Given this list of marker genes Set, Smpdl3a, Fth1, Psmd8, Coro1a, Gpnmb, Phb2, Krt15, Tgfb1i1, Kmt2b, Ptgir, Gpsm3, Milr1, Srsf11, Psmb8, Drap1, Fam89b, Hnrnpa0, Ttyh2, Letm2, Efhd1, Ywhae, Aif1l, Atg3, Pcolce2, Sntb2, Ly6a, Tomm40, Dbnl, Tpm3, Tsn, Cebpb (NCBI Gene Id 18031), Dusp3, Nfkbia, 4933434E20Rik, Plaat3, Stub1, Cebpd, Lysmd2, Rhog, Anp32b, Ddah2, Vps72, Pkig, Gsk3a, Mllt6, Tmeff2, Mboat7 (membrane bound O-acyltransferase domain containing 7), Gpx3, Shisa5, Csnk2b, Tcn2, 1700019D03Rik, Mtarc2, Fus, Abhd17a, Igfbp7, Atp5f1c (NCBI Gene Id 80670), Atp6v0c, Arf5, Adrm1, Cd248 (NCBI Gene Id 70445), Pex14, Akt1s1, Icam1, C1qbp, Tppp3, Bsg, Sdhc, Fosl2, Exosc7, Tmem242, Dpep1, Rpsa, Nudc, Usp18, Metrnl, Lamtor1, Dpysl3, Cdc123, Lgals9, Sfxn1, Pold4, Lmo4, Tax1bp3, Mdh1, Pamr1, Slc25a3, BC005624, Apoe, Ly6c1, Rarres2, Psmd12, Rpl13, Exosc5, Dnajb1, Lurap1l, Gatd3a, Hmg20b, Eri3, Capg, Mgst1, Basp1, Psmb10, Cdkn1c, Cd63, Commd10, Anxa1 (NCBI Gene Id 319730), Ube2r2 (ubiquitin-conjugating enzyme E2R 2), Cebpg, Tmem234, Krt17, Arl6ip5, Acvrl1, Znhit1, Rsrp1, Mitf, Ldha, Rab11b, Hdgf, Jund, Timp3, Anp32a, Ndufs7, Eif1, Psmb6, Sdf2l1, Tcf7l1, Htra2, Chmp2a, Gstt1, Ndufb7, Rplp0, Tuba1c, Cask, Naxe, Sp110, Psmb4, Ift57, Rrp1 (ribosomal RNA processing 1), Arl6ip1, Numbl, Fis1, Cd52, Tnfaip2, Tmem150a, Klf2, Vegfd, Kdelr1, Srgap1, Gabarapl2, Dhrs4, Cuta, Lias, Id3, Dapk3, Gas7, Emc7, Macroh2a1, Bag1, Rab13, Nudt3, Sbsn, Naxd, Efhd2, Rps3a1, Rps5, Nfe2l2, Litaf, Ifitm2, Zfp36l1, Eif5a, Anapc11, Ak2, Fam124a, Pdlim4, Fos, Psip1, Rbpj, Txndc12, Ubb, Krt14, Dcakd, Sdc4, Mbp, Map1lc3a, Rpl13a, Gpx4, Ddrgk1, Ifi35, Ube2m, S100a16, Chmp4b, Malat1, Ppp1ca, Tle5, Eya2, Angptl2, Polr3gl, Cygb, Creb5, Hnrnph3, Cys1, Tmed1, Trappc3, Atp2b1, Bcl7c (NCBI Gene Id 233901), Ets1, Atn1, Nbl1, Casp4, Ramp2, Gadd45b, Pde8a, Snrnp70, Trir, Comt, Prpf38b, Cabin1, Prdx6, Tmem250, Smc3 (structural maintenance of chromosomes 3), Rps3, Ehd1, Fcgr3, Fam3a (FAM3 metabolism regulating signaling molecule A), Sod2, Atg101, Laptm4a, Phlda3, Fgf18, Klf6, Smim10l1, Jak1, Selenok, Scand1, Smarcb1, Brd3, Sod3, Dctn3, Twist1, Tmem9, Arf6, Apbb1ip, Cnrip1, Cfl1, Il6, Snrpb, Atp5f1d, Hagh, Cltb, Arl8a, Srrm2, Ubb-ps, Txn2, Tomm6, Nfkbiz, Ptp4a2, Pih1d1, E2f4, Scn1b, Selenom, Erh, Mier1, Tmem160, Kdm6b, Ier3, Kpna4, Hsd11b1, Plscr3, Il3ra, Aamp, Ccl11 (C-C motif chemokine ligand 11), Nras, Lamtor4, Trappc6b, Syngr2, Clec3b, Adh5, Ifi211, Vps29, Tuba4a, Zfp36, Cald1, H2-K1, Hs3st1, Szrd1, Il11ra1, Gnb2, Pebp1, Ftl1, Gng10, Polr2g, Dcn, Mrps12, Fkbp2, Rabac1, Nsd3, Zmat5, Atp6v1g1, Bri3, Tmem106a, Lamtor3, Rassf1 (NCBI Gene Id 56289), Gnb1, Dpysl2, Kmt2e, Vegfb, Gadd45gip1, Irf7, Palm, Prdx5, Zfpl1, Myoc, Ccl2, Gnptg, Pltp, Adprh, Ssbp4, Slc43a3, Dact2, Ltbr, Srsf5, Ebf1, Dda1 (DET1 and DDB1 associated 1), Junb, Cd74, Mospd3, Prelp, Fdx1, Inmt, Naa80, Ntan1, Psmc2, Has1, Scara3, Med28, Vti1b, Gspt1, Psmc4, Ecm1, Tprg1l, Pim1, H2-M3, Rexo2, Wbp2, Tpt1, Cdc37, Ybx1, Arpc4, Ppfibp1, Nt5c3b, Plscr1, Gngt2, Sf3b4, Mdh2, Acin1, Pabpn1, Mrps24, Srp14, Samd4b, Serbp1, Rap1a, Rbpms, C3, Micu3, Psmd4, Clic4, Cdk2ap2, Mrps18a, Hspa4 (NCBI Gene Id 15525), Polr2e, Maf, Iigp1, Duoxa1, Nabp2, Dmkn, Mxra7, Anp32e, C1qb, Tnfsfm13, Lgals3, Cxcl1 (C-X-C motif chemokine ligand 1), Ercc1, B2m, Psme1, Capzb, Tmem88 (NCBI Gene Id 67020), Ptov1, Ppp1r35, Sf3b2, Pdcl3, Bcl9l, Mmp14, Map2k2, Mustn1, Gstp1, Bcl3, Rbm25, Swi5, Tmem126a, Plin2, Eif3f, Tnfsf13b, Gnai2, Cyba, Raly, Rbm42, Sumo3 (small ubiquitin-like modifier 3), Ces1d, Marcks, Smc6, Ino80e, Sumo1, Tcf7l2, 1110004F10Rik, Tagln2 (NCBI Gene Id 78395), Oaz1, Etfb, Lrp1, Lrrc8a, Lifr, Cacybp, Aip, Zbtb7a, Dpt (dermatopontin), H2-Aa, Gpm6b, Ybx3, Gstm1, Cdc42ep5 (NCBI Gene Id 97398), Qpct, Snrpa, Klf9, Plin3 (NCBI Gene Id 66905), Ccn3, Oaf, Il17d, Arhgdia, Tnfsf12, Shfl, Oaz2, Pfn1, Eef1d, Tmem14c, Vat1, Ece1, Rab5c, Ptpn1, Gltp, Rala, Arl3, Ctsb, Wasf2, Rack1, Spr, Eif6, Stx4a, Tmod2, Ddhd2, P2ry12, Vcf1, Ldhb, Park7, Cuedc2, Anxa8, Vps28, Cnppd1, Ube2l6, Hsp90ab1, Tmed4, Emd, H3f3b, Nfix, Lsm2, Ccdc85b, Fbxo6 (NCBI Gene Id 99978), Socs1, Cndp2, Psmd7, Babam1, Clmp, Tra2a, Ctsz, Adm, Tmed9, Ubxn4, Pgd, Particl (NCBI Gene Id 78108), Fam32a, Tmt1a (thiol methyltransferase 1A1), Retnla, Fdps, Ypel3, Tpd52l2, H2-Eb1, Dgcr6, Ptms, Camk2n1, Prr13, Mrpl12, Ubl7, Bin1, Chd4, Pnrc1, Rras, Tecr, Ostc, Ssna1, Ralbp1, Aup1, Idh3b, Rpl4, Tex261, Bst2, Arpc3, Ly6e, Lcn2, Bag3, Brk1, Phf11d, Pcnp, Nubp2, Tm4sf1, Ap2s1, Crip2, Cirbp, Czib, Mrpl24, Cox5a, Kif2a, Irf1, Klf13, Aldh2 (aldehyde dehydrogenase 2, mitochondrial), Pip4p1, Ift27, Senp6, Rbms1, Vapb, Lrrn4cl, Eif1a, Pdlim2, Renbp, Cyp4b1, Lgals3bp (NCBI Gene Id 19039), Emc10 (NCBI Gene Id 71332), Ctss, Snrpc, Vcam1, Tbcb, Mfge8, Myc, Plekhj1, Uchl1, Rnase4, Ssbp3, Tnxb, Dnaja1, Tek, Dhrs3, Npc2, Ndufa10, Nfic, Cd8b1 (NCBI Gene Id 12526), Aig1, Ccdc124, Tsen34, Pdpn, Cd151, Ube2e2, Ptma, Ubxn1, Osr1, Cd9, Limch1 (LIM and calponin homology domains 1), Cyb5r3, Ube2e1, Gprc5b, Selenow (NCBI Gene Id 20364), Mlf2, Ngf, Hras, Dlgap4 (NCBI Gene Id 98882), Gapdh, Cpne8, Steap3, Ap1s1, Sp100, Clu, Adora2b, Pdlim1, Copz1, Ostf1 (NCBI Gene Id 98144), Ldaf1, Filip1l, Emc4, Elof1, Nfkbib (NCBI Gene Id 18036), Cyb5a, Adamtsl3, Tspo (translocator protein), Ccnl1, Cotl1, Naa10, Elf1 (NCBI Gene Id 13709), Ier2, Ube2v1, H2-T23 (NCBI Gene Id 15040), Rab1b (NCBI Gene Id 76308), Ctnna1, Arpc1b, Spry1, Il34, Zfp503, Sbds, Cryab, Hnrnpd, Sri, Mmp24os1, Anxa3, Myd88, Erp29, Lyz2, Lmo2, Atp6v0b, St3gal6, Aebp1, Lgmn, Edf1, Dtnbp1, Cdkn1a, Hsd17b12, Tmem176b, Syf2, Sox4, Trim47, Brd4, H2-D1, Pin1, Maf1, Nsg1, C4b, Mrpl58, Ifitm3, Meg3, Prnp, Manbal, Pdlim7 (NCBI Gene Id 71959), Map1lc3b, Csnk1e, Scamp3, Eif3k (eukaryotic translation initiation factor 3, subunit K), Hsp90aa1, Tcf4, Pla1a, Tmem50a, Gabarapl1, Dtx3, Hmgb1, Thbd, Clic1, Dpp4, Ly6h (lymphocyte antigen 6 family member  H), Spag7, Prrx1, Thra, Tmsb10, Max, Slfn5, Spry2, Rbm26, Grina, H2-Ab1, Use1, Cbr1, Psme2, Mmp11, Lsp1, Calm3, Prelid1, Otub1, Ccl7, Camk1, Eif5, Impact, Mea1, Rhoc, Rrad, Hmox2 (heme oxygenase 2), Pcsk6, Fkbp8, Grpel1, Cmtm3, Rps10, here is a description of the gene set: studied in species Mus musculus Mouse Gene Set: TABULA_MURIS_SENIS_GONADAL_ADIPOSE_TISSUE_MESENCHYMAL_STEM_CELL_OF_ADIPOSE_AGEING from publication Tabula Muris Consortium (PMID 32669714)